Given this list of marker genes FAH, CPOX, ALAD, HMBS, PPOX, here is a description of the gene set: studied in species Homo sapiens Human Gene Set: HP_ELEVATED_URINARY_DELTA_AMINOLEVULINIC_ACID Elevated urinary delta-aminolevulinic acid An increased concentration of 5-aminolevulinic acid  in the urine.